Given this list of marker genes Fap, Cst3, Idua, Vsir, Itgb1, here is a description of the gene set: Mouse Gene Set: GOBP_REGULATION_OF_COLLAGEN_CATABOLIC_PROCESS species: Mus musculus Any process that modulates the rate, frequency or extent of collagen catabolism. Collagen catabolism is the proteolytic chemical reactions and pathways resulting in the breakdown of collagen in the extracellular matrix.